Given this list of marker genes Zfp781b, Klra8, Zfp729a, Bltp3a, Inka2, Rest, 2210418O10Rik, Zfp930, Gm14296, Rreb1, Dclk1, Zfp275, Fmo9, Gm6712, Zfp971, Sema3a, Cbl, Hrh1, Bcas3, Alx4, Zbtb40, Mapt, Creb3l3, Slc7a3, Nos1, Zfp970, Ube2r2 (ubiquitin-conjugating enzyme E2R 2), C1s2, Gm14325, Boc, Zfp951, Zfp87, Gm2026, Kmt2a, Nhsl3, Pou3f2, Riok3, Zfp960, Rbm41, Gm10778, Ppargc1a, Cdh2, Mmp25, Cplx2, Lrp4, Cmtm6, Zfp976, Gabrb2, Zfp708, Cyb5r3 (cytochrome b5 reductase 3), Dlg2, Lrit1, Cacng6, Ttc33, Slc4a8, Sugt1, Gm14308, Ogt, Nek9, Zfp493, Cmtr2, Tmem178b, Sertad1, Mef2d, Marchf9, Zfp965, Arhgef7, Naa30, Dio2, Epc2, Rtn4rl1, Klra9, Gtf3c4, Pabir1, Itih5, Rnf216, Zfp936, Vps13c, Mtmr4, Czib, Zfp935, Gdf6, Gm20939, Ralbp1, Tmem9, Fas, Rap1b, Asph, Exo1, Tmod2, Gm14322, Cd3g, Ppp2r1a, Ror1, Eva1a, Klf14, Zfp811, Ret, Zfp937, Wdr37, Zfp120, EU599041, Gm6710, Zfp1008, Dynlt5, Gm5141, Med1, Plxna1, Prkca, Plxna2, Irs1, Fzd5, Lta, Kcnt2 (NCBI Gene Id 240776), Zfp973, Smpdl3b, Cnot7, Zfp869 (NCBI Gene Id 98906), Agap1, Zeb2, Homez, Gm14326 (predicted gene 14326), Gprc5b, Zfp975, Zfp738, Snph, Ddo, Plb1, Galnt6, Dscaml1, Acoxl, Tgfb1i1, Prickle2, Daam1, Kcnn3, 2010315B03Rik, Lamc1, Zfp1009, Klra3, Dpysl2, Zfp967, Psd3, Tardbp, Zfp97, Camk2g, Arpin, Gm14391, Prok2, here is a description of the gene set: Genes predicted to be targets of miRBase v22 microRNA mmu_miR_3473c in miRDB v6.0 with MirTarget v4 prediction scores > 80 (high confidence targets). species: Mus musculus from publication Chen Y, Wang X (PMID 31504780) Mouse Gene Set: MIR_3473C